The following is a description of a gene set: species: Homo sapiens Aplasia/Hypoplasia involving the carpal bones Absence or underdevelopment of the carpal bones. Human Gene Set: HP_APLASIA_HYPOPLASIA_INVOLVING_THE_CARPAL_BONES, and this is the list of marker genes: RBM8A, SALL4, KIF22, NANS, LMBR1, WNT7A, TRPV4, EIF2AK3, XRCC2, EXOC6B, GNPTAB, RSPRY1, COMP, RECQL4, ALDH18A1, DYM (NCBI Gene Id 54808), COL2A1